Given this list of marker genes Txnrd3, Selenot, Txnrd2, Txndc17, Nxn, Pgk1, Txndc2, Txn1, Txnrd1 (NCBI Gene Id 50493), here is a description of the gene set: Mouse Gene Set: GOMF_PROTEIN_DISULFIDE_REDUCTASE_NAD_P_H_ACTIVITY studied in species Mus musculus Catalysis of the reaction: protein-dithiol + NAD(P)+ = protein-disulfide + NAD(P)H + H+.